The following is a description of a gene set: We investigated at which stage of maturation commitment to a stable Foxp3-expressing phenotype takes place. We assessed stability of Foxp3 expression in thymic Foxp3+ Treg subsets of different maturity, defined by CD24 expression. Next we compared gene expression profiles of Foxp3+ Treg subsets (+) of different maturity (24lo, 24int, 24hi) and could identify a set of genes that were specifically up or downregulated in Foxp3+ Tregs, but not in Foxp3- conventional T cells, in a maturation-dependent manner. studied in species Homo sapiens Human Gene Set: GSE42021_CD24INT_VS_CD24LOW_TCONV_THYMUS_DN from publication Toker A, Engelbert D, Garg G, Polansky JK, Floess S, Miyao T, Baron U, Düber S, Geffers R, Giehr P, Schallenberg S, Kretschmer K, Olek S, Walter J, Weiss S, Hori S, Hamann A, Huehn J (PMID 23420886) Genes down-regulated in thymic T conv: CD24 int versus CD24 low., and this is the list of marker genes: IFIT3, PROC, CTBS, MAB21L4, RUSC1, WWC3, KRT86, HLA-F, EIF2AK2, TSC22D1, SRC, SOX4, KLHL35, EHHADH, SOX9, SEC14L1P1, FMR1, DHFRP3 (NCBI Gene Id 1720), TIPRL, PLSCR1, MTCL2, ELF1, NRAS, TRIM38, IFIT5 (NCBI Gene Id 24138), CFHR4, KLHL11, PON3, IGKV4-1, TMCC1 (NCBI Gene Id 23023), ATP2B4, CHMP5, CYREN, HES2, TMEM62, TRIM26, C11orf68, CYTH1, OAS1, OR1A2, H2AC13, MAGEL2, MGAT3, SCAMP1, PDK2, RBBP6, ID3, TFAP2C, SP110, TRANK1, LOX, WNT1, PML, SCNN1G, WWTR1, LMNA, RIGI, GTPBP2, LEMD3, TRIM14, IFITM2, SMAGP, KCTD17, BFSP2, CD164, PAPSS1, SPATA31C2, SMOX, NAPA, BICD1, AMIGO2, EML2, TENT5A, MAP4K3, DSP, TUFT1, IFI27, IFIT1, HLA-C, NOX5, MPPED1, EDN1, RPL13P5, RGS11, IFITM1, KIAA0513, IFIT2, PPP1R3C, HERC6, MX1, PRKD2, FZD7, RSAD2, PPFIBP2, BLZF1 (basic leucine zipper nuclear factor 1), PHF11, LMO2, TF, LRRC8D, MUC4, ZBED5, VEZF1, LAMC3, MYBL1, EVC, HBEGF, ISG15, IRF7, IFIH1, GATA3, DDX60, TRIM5, BCL2L13, KCNF1, ZFAND5 (NCBI Gene Id 7763), NAT8, SMARCA5, OAS3, AAK1, SHFL, DAPP1, MTARC1, BTN2A1, CCN2, TRIM22, IFI44L, USP18, MORC4, BMPR2, TLK2, SPATS2L, TMEM50A, IL20RA (NCBI Gene Id 53832), IFI44, PALLD, PRKN, EPAS1, PDGFD, IER2, LAMP3, CAVIN2, LIPA, HTR1D, CUL4B, RAB33B, HMOX1, SP100, CDC42EP3, PIK3CA, KATNIP, CD96, PPARG, OAS2, MRPS18C, LCN1, SLC7A11, CDC34, TOB1, TLE1, ETS2, SIDT1, SCARB2, LAMP2, LPAR1, CNPY3, OASL, VLDLR, BST1, TDRD7, TPTE, SAMD9, SUOX, EXT1, OPHN1, GNAI1 (G protein subunit alpha i1), CHMP2A (charged multivesicular body protein 2A), KCNJ12, ISG20, LGALS9, PARP12, CYBRD1, C5 (complement C5), MAP2K7, TREX1, EGLN1, TNFSF10, IRF9 (interferon regulatory factor 9), PTCH2, EHD4, HERC5, THEMIS2, GABRE, NBR1 (NBR1 autophagy cargo receptor), MYH1, IFI6, NUAK1, JADE2, MX2, ZCCHC2, MYD88